Given this list of marker genes IER3, HPCAL1, SQOR, PGM1, SELL, ACTR1A, ACADL, GNB5, CNN3, TRIM21, RBBP4, IPO7, TBC1D1, WT1, PML, RNASEH2B (ribonuclease H2 subunit B), RSAD2, C1QC, IL18R1, LDLR, GAR1, PKP4 (NCBI Gene Id 8502), SLC11A2, CD72, GMNN, RANBP10, S100A11, RPP14, CST7, APOE, GNA13, SLC25A47, INCENP, VPS35, TRIM46, MTDH, BLK (NCBI Gene Id 84743), CYB5A, IVD, CTLA4, FRRS1, NOLC1, SNW1, TMEM150A, GALC, POU6F1, RHOQ, CHEK1, TDP2, MBD1 (methyl-CpG binding domain protein 1), ARG1, PDPN, IL2RA, ILF3, SMNDC1, WDHD1 (WD repeat and HMG-box DNA binding protein 1), RMND1, SLC1A5, TMEM14C, NHERF1, GEMIN5, NUDT19, CDK11B, MRPL16, ITGA4, CWC22, GCLM, TRMT1, SLC48A1, YY1, SOD1, MTHFD2, TMEM70, KCTD12, DCN, PIM1, ISL1, DBI, PTGER2, SLFN12L (schlafen family member 12 like), EMD, MFF, PLA2G12A, SUCLG2, GCOM1, LY6D, GOLGA5, MARK3, IL27RA, CHADL, DPAGT1, IGF2R, USP38, EPB41L4A-AS1, PCBP2, HGSNAT, DUSP12, ANXA2, WRN, GALNT3, SEMA4D, SRP9, AKAP9, SC5D, D2HGDH, PLK1 (NCBI Gene Id 5347), METTL8, PPOX, GAS2, EIF2AK3, PRPS2, MNS1, TBL3, CKB, DENND2B (DENN domain containing 2B), TAPBP, TM7SF2, FAM167B (NCBI Gene Id 84734), FURIN, LGALS3BP, IRF1, EIF2A, ZMYND11, RPL36A, KDM5B, NDST1, WARS1, TPD52, ALDH1A1, DNAJC15, USP39, SNHG6, AGTRAP, CLDN7, BRI3, NTMT1, PDLIM1, S100A6, BRWD3, RXRG, YWHAQ, CSN2 (NCBI Gene Id 1447), KIF23, DNAJC3, ADCY4, CRNKL1, MAP7, BANF1, HDAC1, ARHGEF3, RCC2, GGCX, POLDIP3 (NCBI Gene Id 84271), SMO, PRIM2, GGH, CRAMP1, MAP1LC3A, MTMR7 (NCBI Gene Id 9108), LGALS3, ATP1B1, AKR1E2, SPG21, ATP6V1D, CNOT1, SNX10, ERO1B, MTIF2, INTS11, IDUA, RECQL (NCBI Gene Id 5965), NF2, CDCA3, HSPA1A, CCNE1, IFNB1, CD8B, CDC25C, ABCD3, TNF, NSD1 (nuclear receptor binding SET domain protein 1), PARP8, CHMP4B, PNP, ANKIB1 (ankyrin repeat and IBR domain containing 1), PDK1, GTPBP4, SEMA6B, DNASE1L2, HAUS5, ANGPTL4, AK2, BLM, MFHAS1, PISD, ACSL5, ICOS, DOCK2, DIAPH3, PCSK1, here is a description of the gene set: Human Gene Set: GSE1925_CTRL_VS_24H_IFNG_STIM_IFNG_PRIMED_MACROPHAGE_DN from publication Hu X, Park-Min KH, Ho HH, Ivashkiv LB (PMID 16148108) studied in species Homo sapiens Genes down-regulated in macrophages primed by IFNG: untreated versus stimulated by IFNG for 24h. IFN-gamma transcriptional responses in control and IFN-gamma primed primary human macrophages